The following is a description of a gene set: Human Gene Set: HP_INCREASED_RED_CELL_SICKLING_TENDENCY Increased red cell sickling tendency species: Homo sapiens, and this is the list of marker genes: BCL11A, HBG1, HBB (NCBI Gene Id 3043), HBG2, KLF1